The following is a description of a gene set: Mouse Gene Set: GOBP_RETINAL_PIGMENT_EPITHELIUM_DEVELOPMENT The progression of the retinal pigment epithelium over time, from its initial formation to the mature structure. The retinal pigment epithelium is the melanin-containing layer of cells between the retina and the choroid that absorbs scattered and reflected light and removes waste products produced by the photoreceptor cells. species: Mus musculus, and this is the list of marker genes: Tbc1d32, Med1, Cldn19, Mfsd2a, Tmem135, Ihh, Ndp, Cfh, Pax2, Slc38a8